The following is a description of a gene set: species: Mus musculus Malate-aspartate shuttle Mouse Gene Set: REACTOME_MALATE_ASPARTATE_SHUTTLE, and this is the list of marker genes: Mdh1, Slc25a11, Slc25a12 (NCBI Gene Id 99450), Mdh2, Slc25a18, Got2, Slc25a22, Slc25a13, Got1